The following is a description of a gene set: Genes up-regulated in NK cells: low dose versus high dose of IL2. Human Gene Set: GSE12198_LOW_IL2_STIM_NK_CELL_VS_HIGH_IL2_STIM_NK_CELL_UP Transcriptional profiling of NKAES-derived NK cells after 7 days of culture compared to primary human NK cells and NK cells stimulated by low or high dose IL2 after 7 days of culture. from publication Fujisaki H, Kakuda H, Shimasaki N, Imai C, Ma J, Lockey T, Eldridge P, Leung WH, Campana D (PMID 19383914) studied in species Homo sapiens, and this is the list of marker genes: ATF1, RBPMS2, C7orf25, LTB, FRMD6 (NCBI Gene Id 122786), DMAP1, RAB40C, TNFRSF18, ETFRF1, DPP8, SDF4, ZNF276, GPA33, FAM133B, DNAJB11, AGPAT5, GGA2, MRM1, ENTPD6, OLA1, TMEM183A, TTC39B, CCNB1IP1, PIGU, RAD54L2, ARMC10, THTPA, HNRNPLL, GEMIN7, SLC29A2, UPF1, RGS20, EXT1, DLC1, MTAP, TRIM21, TP53BP1, GALNT11, TMEM87A, UBC, LPIN2, ZDHHC20, DNAJB6, MAPRE2, TCF7, FOXN2, ITCH, ZC3H18, ACHE, ZNF142, SPRED2, HLA-C, RSPH9, TSR3 (NCBI Gene Id 64721), SMAD2, PSMD2, AFG2A, KDM3B, ENO3, SLC66A2, PPP1R14B, CDC5L, DGLUCY, DRAP1, TP53INP1, CSNK1D, PRPF40B, PARN, TBRG4, LARP1, AHCYL1, GPN1, PCM1, BZW2, C18orf32, ZFAND2A, RASGRP1, LRP4, MRPL54, CCL17, VASN, ATG16L1, SLC39A3, MAP3K4, NIPBL, CIAO3, ELAVL3, ZBTB33, ARMCX5, FBXO28, PRRG2, ATXN2, EPHX1, SEC31A, ZMIZ2, CNOT7, VOPP1, CCL28, FOXRED1, C1orf43, EIF3L, SLC38A1, XPC, WDR83OS, MTREX, MBD3, ACBD3, SAC3D1, EPSTI1, HACD3, ADPRS, ATXN7L3, SEC24B, CD53 (NCBI Gene Id 963), LLGL1, CREBZF, IKBKE, NFATC1, TMUB1, INTS13 (integrator complex subunit 13), IGF1R, TLK2, MTDH, C3orf62, IER3IP1, TAF1D, ITM2A, PTP4A3, AVL9, BACH2, ARFGAP1, PYROXD1, HNRNPDL, PHPT1, MTX2, TSNAX, ELP3 (NCBI Gene Id 55140), TUSC2, VAC14, MED28, GLIPR1, CLK2, LAS1L, NCOR2, GADD45B, POLR3D, FMNL3, PRPF8, FNTB, BUD13, ZC3H3 (NCBI Gene Id 23144), TRIB1, SH3BP2, CHIC2, SURF2, SAMSN1, PLA2G6, TEFM, RBM28, CNIH2, ABCF3, ARFRP1, ZNF565, HIF1A, UTF1, INPP5K, RAB11B, CD96, SLC2A5, PSMB7, MTARC2, DDX46, MS4A6A, BMS1, RNF123, MED23, ITSN2, FAM98C, EIF3E, SMIM19, ASB6, ATP1A1, BTG2, ENTR1, BNIP1, TNF, CLK4, IREB2, TNMD, MECR, GLI2, DNAJB5, UNC50, ALG3, PSD, KANSL1L, HOXA7, RNF6, ICE1, FAM174B